The following is a description of a gene set: Mouse Gene Set: REACTOME_ASYMMETRIC_LOCALIZATION_OF_PCP_PROTEINS Asymmetric localization of PCP proteins species: Mus musculus, and this is the list of marker genes: Psma3 (proteasome subunit alpha 3), Ubc (NCBI Gene Id 77003), Psmd12, Psmb2, Psma4 (proteasome subunit alpha 4), Psmc5, Psmb6, Fzd7, Psmb5 (proteasome (prosome, macropain) subunit, beta type 5), Fzd4, Uba52, Smurf2, Smurf1, Psmb7, Ubb, Fzd3, Psmc2, Psmd13, Psmd8, Prickle1, Fzd1, Dvl2, Psma1, Psmb4, Wnt5a, Fzd2, Psma5, Psmc1, Psmb3, Psmd14, Psmb1, Adrm1, Psmc3, Uba52rt, Psmd7, Psmd2, Pard6a, Psma7, Psma2, Fzd8, Psmd6 (proteasome (prosome, macropain) 26S subunit, non-ATPase, 6), Psmc4, Psmc6, Psmd3, Rps27a, Psmd1, Psma6, Fzd5, Psmd11